The following is a description of a gene set: studied in species Mus musculus Polymerase switching Mouse Gene Set: REACTOME_POLYMERASE_SWITCHING, and this is the list of marker genes: Rfc1, Rfc5, Rfc4, Pold2, Pcna, Rfc3, Pold3, Prim2, Pola2, Rfc2, Pola1, Pold4, Prim1, Pold1